Given this list of marker genes Etfbkmt, C1qtnf3, Bmp2, Erlin1, Mup5, Dbi, Serpina12 (serine (or cysteine) peptidase inhibitor, clade A (alpha-1 antiproteinase, antitrypsin), member 12), Malrd1, Cry1, Amdhd2, Insig2, Ppp2ca, Insig1, Fbp1, Mtcl2, C1qtnf12, Dgat2, Adipoq, Dkkl1, Dkk3, Pgp, Sox9, Slc22a13, Gfi1, Ep300, Rd3, Acmsd, Ch25h, Plek, Atp5if1, Cda, Akt1, Erlin2, Tcf7l2, Erfe, Pfkfb1, Fmo2, Kat2a, 3110082I17Rik, Prkg1, Pid1, Mup4, Sod1, Ddit4, Nfkb1, Mst1, Slc25a12, Snai2, Acadl (NCBI Gene Id 98523), Wnt4, Myog, Entpd1, Flcn, Parp1, Fmo4 (NCBI Gene Id 52368), Fis1, Cnr1, Ins1, Ceacam2, Sirt1, Apoc1, Fmo1, Sirt6, Mup11, Gmppa, Appl2, Sirt4, Tigar, Mir214, Snai1, Prox1, Oaz1, Hdac4, Slc27a4, Wdtc1, Actn3, Sik1, Plin5, Ppara, Gck, Ncor1, Il6, Nupr1, Prmt3, Aldob, Apoc3, Mup3, Xpc, Mup1, Akr1c18, Clk2, Sik2, Atcay, Fgf15, Dcaf5, Mtch2, Git1, Gpi1, Obp2a, Isyna1, Ier3, Apoe, Idi2 (isopentenyl-diphosphate delta isomerase 2), Ceacam1, Stat3, Tspo, Pgk1, Brca1, Prkaca, Rest, Cbfa2t3, Acadvl, Cyp27b1, Atp2b4, Klhl25, Ppargc1a, Pibf1, Ubr4, Acacb (acetyl-Coenzyme A carboxylase beta), Lepr, Ins2, Trp53, Mir199a-2, Trib3, Usp7, Cyp7a1, Ggcx, Mfsd2a, Gchfr, Bmp5, Trim63, Mup2, Slc4a1, here is a description of the gene set: studied in species Mus musculus Mouse Gene Set: GOBP_NEGATIVE_REGULATION_OF_SMALL_MOLECULE_METABOLIC_PROCESS Any process that stops, prevents or reduces the frequency, rate or extent of a small molecule metabolic process.